Given this list of marker genes Myod1, Mapk14 (NCBI Gene Id 26416), Cdh15, Cdon, Ctnnb1, Myf6, Tcf3, Cdh2, Mapk12, Cdc42, Myog, Mapk11, here is a description of the gene set: This event has been computationally inferred from an event that has been demonstrated in another species.<p>The inference is based on the homology mapping from PANTHER. Briefly, reactions for which all involved PhysicalEntities (in input, output and catalyst) have a mapped orthologue/paralogue (for complexes at least 75% of components must have a mapping) are inferred to the other species. species: Mus musculus electronically inferred by orthology from the curated human pathway part of: Developmental Biology Reactome Pathway: Myogenesis